Given this list of marker genes Ttc14, Srsf6 (NCBI Gene Id 98904), Papolb, Rbfox2, Prpf18, Esrp1, Rbm12b2, Clasrp, Hnrnpr, Lsm7, Aimp1 (aminoacyl tRNA synthetase complex-interacting multifunctional protein 1), Papolg, Cfb, U2surp, Eif3g, Traf6, Cd2bp2, Rbpms2, Enox1, Synj2, Celf2, Cyp4f18, Hnrnpa1, Rbmxl1, Pum1, Ssb, Rbm17, Ncbp2, Tert, Tmed10, Mrm3, Rps28, Ilkap, Adam5, Rbms3, Alkbh8, Sf3b3, Srp54a (signal recognition particle 54A), Rnaseh2a, Rps29, Fxr2, Pabpc5, Rbm22, Naa38, Srp9, Alyref2, Mettl3, Xrn2, Rnu1b6, Puf60, Fbl, Exosc7, Ddx3x, U2af1, Snrpd1, G3bp1, Oas1g, Rbmx, Eif4e2, Tarbp2, Zfp830, Srsf12, Ddx6, Rps4x, Igf2bp3, Afg3l2, Exosc9, Nxf7, Dhx8, Bard1, Abcb4 (ATP-binding cassette, sub-family B member 4), Sf3b2, Mbnl1, Cpeb4, Boll, Npm1, Ro60, Vmn1r26, Fmr1, Rbms1, Pspc1, Celf1, Papola, Sltm, Pcolce, Rbm15b, Hnrnpd, Snrpa, Eif3b, Mrps28, Rbm39, Cstf2, Rbm8a, Rpl19, Aco1, Hnrnpc, Tial1, Rngtt, Prpf8, Rbm4, Prpf4, Srsf4, Eif4e3, Spop, Srsf10, Cpsf3, Smn1, Rbm43, Sf3a2, Dhx16, Ddx5, Rbmy, Adar (adenosine deaminase, RNA-specific), Ppargc1a, Ilf3, Rbm33, Lsm8, Fus, Ppp1r8, Ankar, Pcbp1, Txnl4a, Rad21, Ralyl, Sf3b4, Eif4a3, Scaf8, Raly, Rps20, Tut1, Snrpa1, Srp68, Polr2g, Rbm12, Rpl22, Tra2b, Celf3, Trmt2a, Rnu1a1, Rnu1b1, Atxn1, Srsf1, Rbm11, Dhx9, Elavl4, Rpl26, Rps23 (NCBI Gene Id 66475), Sart3, Snrpd3, Uhmk1, Clk4, Dnajc17, Sf3a1, Eif2d, Zbp1, Lingo1, Snrpg, Sf3a3, Oas2, Rps14, Ttc39a, Hnrnpa2b1, Mrpl11, Trim21, Eif2ak2, Hnrnph1, Htatsf1, Ppie, Fxr1, Elavl2, Auh, Snrnp40 (small nuclear ribonucleoprotein 40 (U5)), Myef2, Ddx56, Srsf11, Park7, Rnu2-10, Rbfox1, Rpl37rt, Eif4h, Msi1, Nip7, Exosc5, Srp14, Pum2, Slc6a8, Nudt21, Pabpc1, Hnrnpm, Oas1a, Rbm34, Rps4l, Supt5, Rps27, Fdx2, Cdc40, Rpl39l, Ddx4, Raver1, Wdr55, Rbpms, Ggcx, Hnrnpl, Sugp2, Rbm38, Msi2, Srsf3, Rbm47, Rps6, Rnpepl1 (NCBI Gene Id 98480), U2af2, Sf3b1, Snu13, Matr3, Hnrnpf, Dhx15, Rpl38, Rpl37, Cirbp, Srsf9, Snrpf, Dhx38, Rps24, Tia1, Srpk2, Clk3, Imp4, Dis3l2, Ddx41, Rbm10, Elavl1, Dnajc8, Slirp, Snrpd2, Secisbp2, Pcbp4, Sf3b6, Snrpn, Sbno1, Elavl3, Tmem163, Srsf7, Syncrip, Snrnp70, Oas3, Cpsf1, Nifk, Exosc8, Pabpc6, Gatc, Srsf2, Prpf3, Prpf40a, Ncl, Snrpb, Cstf1, Rnmt, Cpsf2, Eftud2, Zfp622, Phf5a, Rbm18, Rbm41, Sfswap, Spen, Snrpb2, Igf2bp1, Adarb2, Cpeb1, Srsf5, Rbm3-ps (RNA binding motif (RNP1, RRM) protein 3), Clp1, Zmat2, Nufip1, Adat1 (adenosine deaminase, tRNA-specific 1, NCBI Gene Id 30947), Pcbp2, Hnrnpdl, Zfp385a, Tdrd7, Rbm6, Zrsr2, Slu7, Rnpc3, Cstf2t, Ddx1, Rnu6, Stau1, Elmod3, Acin1, Rbmxl2, Imp3, Ciz1, Lsm2 (LSM2 homolog, U6 small nuclear RNA and mRNA degradation associated), Zmat4, Nono, Dazap1, Rbm19, Ankrd33b, Lsm11, Snrnp35, Smc1a, Taf15, Zfp346, Eif4a2, Pum3, Prpf40b (pre-mRNA processing factor 40B), Ptbp1, Pskh1, Naa12, Rpl9, Rpl8, Mcts2 (malignant T cell amplified sequence 2), Rbm28, Cpsf4, Mrpl23, Pabpn1, Ergic2, Ppp1r14b, Virma, Gm21379, Prmt2, Ppargc1b, Exosc4, Zfp638, Poldip3, Celf5, D1Pas1 (NCBI Gene Id 98517), Ddx39b, Rbm3, Hnrnpu, Ddx21, Rnu12, Rpp14, Nop9, Rps9, Eral1, Bicc1, Qki, Rpl11, Lsm4, Ewsr1, Rbm31y, Ddx24, Ddx19a, Ddx25, Srek1, Hnrnph2, Srrm1 (serine/arginine repetitive matrix 1), Clk1, Hnrnpk, Rps13, Adad1, Celf4, Rpl32, Ddx19b, Rbmx2 (RNA binding motif protein, X-linked 2), Snrpc, Rpl39, Dcaf1, Ddx20, Rdm1, Rnaset2b, Clk2, Dnd1, Snrpe, Csde1, Enox2, Dicer1, Cstf3, Ddx39a, Rpl7, Wbp4, Prmt1, Hnrnpab, Bclaf1, Col4a3 (collagen, type IV, alpha 3), Son, Rps11, Rbm25, Celf6, Slc25a4, Rpl12, Nxf1, Srpk1 (serine/arginine-rich protein specific kinase 1), Rbm4b, Lsm1, Ptbp2, Rbm12b1 (RNA binding motif protein 12 B1), Rnu1b2, Ppil4, Oasl2, Dis3, Rbms2, Brca1, Dazl, Srp19, Sugp1, Rbm5, Slbp, Rbm45, Akap17b, Eif4g2, Rbm14, Rnps1, Cdk9, Cpeb3, Polr2a (NCBI Gene Id 20020), Rae1, Ppm1g, Zfp740, Pabpc2, Akap1, Brwd1, Hnrnpa0, Grsf1, Htd2, Rnpep, Eif4g3, Tnrc6c, Sf3b5, Sfpq, Tsn, Mak16, Tlr5, Rbm7, Nelfe, Cnot4, Hnrnpll, Trmt1l, Csad, Ybx1, Hnrnpa3, Rnasel, Esrp2, Pabpc4, Tardbp, Cpsf7, Eif4e, Prpf6, Zcrb1, Alyref, Nol8, Rsrc2, Rbm42, Rps7, Safb2, Prpf4b, Rbm26, Ltv1, Ptbp3, Afg3l1, Pcbp3, here is a description of the gene set: studied in species Mus musculus mRNA processing Mouse Gene Set: WP_MRNA_PROCESSING